The following is a description of a gene set: Human Gene Set: HP_POOR_HEAD_CONTROL Difficulty to maintain correct position of the head while standing or sitting. Infant head lag is observed when the head seems to flop around or lags posteriorly behind the trunk. Several articles have maintained that head lag should be absent by age 3 to 4 months. Poor head control studied in species Homo sapiens, and this is the list of marker genes: TRAK1, HACD1, SDHD, GEMIN4, CYFIP2, SPTBN2, MYL2, PLP1, DHFR, NDUFS6, GNPTAB, MT-ND3, ALG2, NDUFB3, GNAO1, DPM2, MYH7, SLC25A1, NDUFV1, FKBP14, NDUFS1 (NCBI Gene Id 55372), CELF2, HCN1, HIVEP2, CLP1, CHAT, DHDDS, NDUFA8, SDHB, NTRK2, SDHAF1, NDUFAF1, EXOSC3, SLC18A2, NUS1, AARS1, DALRD3, SLC16A2, NDUFV2, CASK (calcium/calmodulin dependent serine protein kinase), NDUFAF3, WARS2, NEUROD2, NACC1 (NCBI Gene Id 112939), NDUFA6, FKRP, COX4I1 (cytochrome c oxidase subunit 4I1), NDUFB10, SCN1A, SYNGAP1, ARX, VARS1, NDUFAF8, SLC5A7, NDUFB11, ADCY5, IFIH1, CACNA2D1, GFM2, LYRM4 (LYR motif containing 4), MPZ, NDUFAF4, KCNA2, DHX16, ATP1A3, CDK19, KCNC2, SDHA, CPLX1, UBA5, NDUFS2, RARS1, AHDC1, GM2A, FOXG1, CNKSR2, OSTM1, NUBPL, TNNT1, CLTC (NCBI Gene Id 9511), PIGP, SYT2, ACTL6B, TREX1, NDUFAF5, ESAM, TRIM8, NDUFS8, YWHAG, VPS50, ATP1A2, CACNA1G, GABRG2, NDUFB9, MICOS13, DPAGT1, CACNA1A, PPP3CA, CAMK2B (NCBI Gene Id 816), PMPCB, NGLY1, NDUFA1, TIMMDC1, SLC35A2, GABBR2, SYNJ1, HSPD1, DMXL2, NDE1, NDUFA10, PIGF, ASPA (NCBI Gene Id 443), DNM1 (dynamin 1), PAFAH1B1, GFPT1, TTN, ZNF526, SLC25A22, TMEM126B, HSD17B10, DAG1, MAP3K20, VAMP1, TMEM63A, MT-ND1, GNB5, NDUFS7, COG8, FOXRED1, COL13A1, RALGAPA1, GRIN2A (glutamate ionotropic receptor NMDA type subunit 2A), AP3B2, NECAP1, GJC2, SCN3A, ITPR1, AGRN (agrin), SCN2A, GPHN, NDUFAF2, CDKL5, MEGF10, SCN8A, PHACTR1, KCNB1, POMK, SMN1, MT-ND2, FHL1, SNAP25, SELENON, PSAP, CAMLG, UFC1, CHRND, WWOX, EXOSC9, SUCLG1, CHRNB1, LAMB2, EEF1A2, SLC18A3, ATP6V1A, GABRA5 (NCBI Gene Id 727729), PIEZO2, NDUFS4, SLC1A2, FZR1, MYO9A, TPM3, SLC13A5, ACTA1, ATP7A, GABRA2, NONO, ALG14, GRIN2D, BOLA3, NDUFS3, GRIN1 (glutamate ionotropic receptor NMDA type subunit 1), TRIP4, ELP2, SIK1 (NCBI Gene Id 54018), COLQ, INPP5E, POLR1A, IREB2 (iron responsive element binding protein 2), HPRT1, MRPS25, IFT140, GRM7, SLC5A6, PIGQ, SLC32A1, PNPT1, HEXA, EBF3, LGI4, CACNA1B, NADK2, ADNP, PACS2, AP3D1, PTS, GALC, FARS2, PNKP, MDH2, PCLO, SLC39A8, KCNA1, SZT2, SLC25A12, ITGA7, SLC38A3, GMPPB, GABRB2, TPM2, MYPN (NCBI Gene Id 84665), FBXL4, SNAP29, DDC, MFSD2A, SCN1B, EARS2, PIGA, SPTBN4 (spectrin beta, non-erythrocytic 4, NCBI Gene Id 80322), LMNA, FBXO28 (F-box protein 28), FGF12, NDUFA13, RARS2, NDUFA11, PET100, PARS2, ALG13 (ALG13 UDP-N-acetylglucosaminyltransferase subunit), AHCY